Given this list of marker genes NFKB1, ABCA8, ABCA1, EEPD1, ZDHHC8, MIR206, ABCA3, ABCG4, PON1, RXRA, TREM2, APOA1, GPS2, ABCG1, CAV1, APOE (apolipoprotein E), NR1H2, PPARG, CES1, ABCA12, ADIPOQ, LRP1, ABCA7, NR1H3, SIRT1, PTCH1 (NCBI Gene Id 8015), PLTP (NCBI Gene Id 5360), here is a description of the gene set: studied in species Homo sapiens Human Gene Set: GOBP_POSITIVE_REGULATION_OF_CHOLESTEROL_EFFLUX Any process that increases the frequency, rate or extent of cholesterol efflux. Cholesterol efflux is the directed movement of cholesterol, cholest-5-en-3-beta-ol, out of a cell or organelle.